Given this list of marker genes Sec24b, Scap (NCBI Gene Id 94123), Trappc4, Trappc12, Sar1b, Sar1a, Trappc6a, Preb, Sec31b (NCBI Gene Id 240667), Cideb, Sec24c, Sec31a, Trappc2, Sec23a, Trappc1 (trafficking protein particle complex 1), Pdcd6, Vapb, Rab1a, Trappc5, Sec24d, Trappc2l, Surf4, Insig1, Trappc3, Sec16a, Mapk15, Trappc11, Tbc1d20, Vapa (NCBI Gene Id 30960), Cul3, Sec23b, Pef1 (penta-EF hand domain containing 1), Sec13, Mia3, Sec24a, Klhl12, here is a description of the gene set: Mouse Gene Set: GOBP_COPII_COATED_VESICLE_BUDDING studied in species Mus musculus The evagination of an endoplasmic reticulum membrane, resulting in formation of a COPII-coated vesicle.